The following is a description of a gene set: studied in species Homo sapiens An abnormal shape or form of the proximal phalanx of the big toe. Human Gene Set: HP_ABNORMAL_MORPHOLOGY_OF_THE_PROXIMAL_PHALANX_OF_THE_HALLUX Abnormal morphology of the proximal phalanx of the hallux, and this is the list of marker genes: RAB23, IHH, FIG4, VAC14, FGFR2, FGFR1, ERF